Given this list of marker genes Gripap1, Cd81, Crk, Crkl, Shank3, Dlg4, Musk, Snx27, Lrp4 (NCBI Gene Id 277398), Dok7 (docking protein 7), Sorbs2, Frrs1l, Zdhhc2, Slc7a11, Shisa7, Fnta, Gsn, Rac1, Ptn, Ssh1, Tnfaip6, Fzd9, Shisa6, Sorbs1, Mesd, Farp1, Grip2, Lrp5, Agrn, here is a description of the gene set: species: Mus musculus Mouse Gene Set: GOBP_REGULATION_OF_RECEPTOR_CLUSTERING Any process that modulates the frequency, rate or extent of receptor clustering.